Given this list of marker genes Rab5c, Rab23, Rab44, Rabggtb, Rab12, Rab15, Ptp4a2, Rab2b, Rab22a, Rab11a, Rab30, Rab36, Rab26, Rab27a, Rab35, Rab10, Rab24, Rab3b, Rab7, Rab6a, Rab32, Rab17 (NCBI Gene Id 98692), Rab13, Rab19, Rab5b, Rab2a, Rab29, Rab7b, Rab4a, Rab40b, Rab18, Rab33a, Rab9b, Rab5a, Rab39b, Rab3c, Rab9, Rab27b (NCBI Gene Id 80718), Rab34, Rab1b, Rab43, Rabggta, Rab20, Rab14, Rab39, Rab1a, Rab11b, Chml, Rab3d, Rab6b, Rab25, Rab4b, Rab3a, Rab8b, Rab37, Rab38, Rab33b, Rab21, Rab8a, Rab31, Rab40c, Chm, here is a description of the gene set: Mouse Gene Set: REACTOME_RAB_GERANYLGERANYLATION RAB geranylgeranylation studied in species Mus musculus